Given this list of marker genes ARAP3, PLEKHA1, PIK3CD, PIK3R1, HSP90AA1, ZAP70, PLCG2, RHOA, KRAS, YES1, SGK1 (serum/glucocorticoid regulated kinase 1), FYN, HCK (NCBI Gene Id 3055), LYN, CYTH1, PLEKHA2, PIK3CA, INPPL1, PIK3CG, FOXO3, RAP1A, HRAS, LCK, CYTH2, SYK, LAT, ADAP1, ARF6, PIK3R3 (phosphoinositide-3-kinase regulatory subunit 3), PDPK1, PIK3R5, BLK, SRC, ARF1, FGR, NRAS (NCBI Gene Id 4893), PIK3R2, PIK3R6, CYTH3, PLCG1, BLNK, DAPP1, PIK3CB, PTEN, RAC1, BTK, ITK, ARF5, here is a description of the gene set: species: Homo sapiens Human Gene Set: PID_PI3KCI_PATHWAY Class I PI3K signaling events from publication Schaefer CF, Anthony K, Krupa S, Buchoff J, Day M, Hannay T, Buetow KH (PMID 18832364)